Given this list of marker genes NUP35, MAML2, DCAF16, ABHD14A, SSB, RPP30, ATXN7, SNRPE, AKAP11, MYLK, PRKRA, TMEM161A, TCERG1, ICE2, UNC119B (NCBI Gene Id 84747), ATP2B1-AS1, ZBTB21, SYNJ2BP, RBM27, MRPL3, PRKAR2B, CAPN7, BUD23, CCT2, DKC1, ZXDB, TTC27, RRN3, BCLAF1, NOLC1, TARBP2, ARHGAP21, UTRN, SCML1, MTR, STMN3, NUP160, TMCC1, C8orf33, HMGN3, SMARCA5, CAVIN2, SMURF2, MBLAC2, TGIF1, RPL5, RNF144A, SRPRB, PCED1B, CLNS1A, CSDE1, RRS1, TCTN3, MATR3, MALT1, TOMM5, KDM2B, VPS13C, DPP4, RICTOR, C2orf42, HSP90AB1 (NCBI Gene Id 3326), NARS2, TATDN1, CXCL5, ODC1, SHQ1, SNRPN, BEX3, EIF3K, MAP3K7CL, G3BP2, ZNF420, EIF3J, NFX1, FLT3LG, RPF1, BNIP3, SLC39A10, CFAP68, OGA, ZFAND1, KLRF1, NDUFB2, TTC22, ILF2, RAB27B, CD28, GNPDA2, NMT2, NOPCHAP1 (NCBI Gene Id 121053), MRPS33, TMEM204, ITK, PCBP1-AS1, NGRN (NCBI Gene Id 51335), METTL4, PRKDC, MAT2B, ZBTB41, TIMM21, PTGES3, EIF3E, VPS36, TFB2M, SACS, ZNF529, ARL14EP, EXOSC6, RBM15, BCL2, MUTYH, HNRNPA0, TTC39C, GNGT2, NIFK (NCBI Gene Id 84365), EEF1G, TUBB1, CISD2, ECI2, FUNDC2, TRIAP1, POLR1F, PLA2G12A (phospholipase A2 group XIIA), UBE2Q2, ABCE1, GARRE1, ESYT1, PAQR8, TXK, MYC, SSX2IP, FMR1, GUCY1B1, H2AC25, ZNF573, RPL15, TMEM18, HNRNPH3, UTP4, TASP1, EEF1A1, ZNF792, SMYD4, ZNF593, WDR4, ZNHIT6 (NCBI Gene Id 54680), PARP1, IPO7, RASGRF2, MPHOSPH10, RPL7A, IKZF5, GPATCH4, SUN1, TADA1, PJA1, BOLA3, DCXR (NCBI Gene Id 51181), FBXO4, RSL1D1 (NCBI Gene Id 26156), SRSF3, FAM135A, SERINC5, PVT1, SNAPC5 (small nuclear RNA activating complex polypeptide 5), YTHDC1, TSEN2, SPARC, ACRBP, GATA3, ZNF14, TOMM70, LRPPRC, ZMYND11, CLIC3, IL27RA, PKIA, MRPL24, NSA2, TREML1, PSMG4, OSTC, DDX20, REV1, HSPD1, ABTB3, ADCK2 (aarF domain containing kinase 2), EHD3, TAF4B, GNL3, BMS1, SH3YL1, NOP14, FBXO21, EIF2B3, IDH3A, BRD1, SCFD2, MAN1C1, here is a description of the gene set: Genes up-regulated in comparison of untreated peripheral blood mononuclear cells (PBMC) versus PBMCs treated with CSF3. Human Gene Set: GSE7400_CTRL_VS_CSF3_IN_VIVO_TREATED_PBMC_UP Granulocyte-colony stimulating factor (G-CSF) is used to boost granulocyte counts in immunocompromised patients, but its effects on the immune system may be counter productive. We tested the hypothesis that G-CSF mobilized peripheral blood stem cell (PBSC) products are immunologically down regulated based on gene microarray analysis. Ten peripheral blood samples from normal donors for allogeneic PBSC transplantation were obtained before and after administration of G-CSF and tested on Affymetrix Human U133 Plus 2.0 GeneChip® microarrays. Significant changes in gene expression after G-CSF mobilization were reported by controlling the false discovery rate at 5%. Immune-related genes were isolated from the data set and categorized according to probe set annotations and a thorough, independent literature search. We found that G-CSF up-regulated inflammatory and neutrophil activation pathway gene expression; however, adaptive immune-related gene expression, such as antigen presentation, co-stimulation, T cell activation and cytolytic effector pathways, were generally down-regulated. Thus, despite significant increases in stem cells, lymphocytes and antigen presenting cells, G-CSF mobilized PBSC allografts exhibit a suppressive adaptive immune-related gene expression profile. Our data provides an explanation for the potentially immunosuppressive effects observed after G-CSF administration. species: Homo sapiens from publication Buzzeo MP, Yang J, Casella G, Reddy V (PMID 17761290)